Given this list of marker genes AMD1, SMS, SMOX, SAT2, PAOX, here is a description of the gene set: The chemical reactions and pathways involving spermine, a polybasic amine found in human sperm, in ribosomes and in some viruses, which is involved in nucleic acid packaging. Synthesis is regulated by ornithine decarboxylase which plays a key role in control of DNA replication. Human Gene Set: GOBP_SPERMINE_METABOLIC_PROCESS species: Homo sapiens